The following is a description of a gene set: To study effects of IFNalpha treatment on monocyte-derived macrophages which may influence susceptibility or resistance to HIV. Genes down-regulated in comparison of control macrophages versus macrophages treated with interferon alpha. studied in species Homo sapiens from publication Greenwell-Wild T, Vázquez N, Jin W, Rangel Z, Munson PJ, Wahl SM (PMID 19556424) Human Gene Set: GSE16755_CTRL_VS_IFNA_TREATED_MAC_DN, and this is the list of marker genes: SLC5A10, TRIM56, NEURL3, FAS, EIF2AK2, POLR3C, STK17A, IRF1, NMI, EBI3, C3orf52, LINC02762, POU3F4, ICAM1, HIVEP2, NUB1 (negative regulator of ubiquitin like proteins 1), OSGIN2, RNF115, SAV1, NLRC5, DCP1A, THAP3 (THAP domain containing 3), IL7R, SYT12, DENND5A, ASH1L-AS1, SMARCE1 (SWI/SNF related, matrix associated, actin dependent regulator of chromatin, subfamily e, member 1), MIR3945HG, BTN2A1, IDO1, HAPLN3, ABTB2, PSMA2, SP110, HESX1, MCOLN2, ATP10A, TRAF1, SEMA3C, WNT5A, BASP1, DUSP5, CXCL10, IL6, FEM1C, SINHCAF, RAB8B, GMPR, OAS3, KIF12, LYN, ZC3HAV1, BCL2L13, SERPINB9, PSMB8, FSD1L, NECTIN2, RNF138, CD40, TNFSF10, NT5C3A, ADPRM, IGFBP4 (NCBI Gene Id 3487), ELL2, ISG15, RNF24, LINC00158, NBN, TNIP3, HS3ST3B1, DHX58, B4GALT5, BMAL2, CXCL11, PSMB9, AKIRIN2, SFT2D2, DYNLT1, C4orf46, HERC6, DNAJB6, GK, PXYLP1, STX11, RIGI, BCL2, LRP12, PPP2R2A, SRGAP2C, TRAFD1, APOL3 (apolipoprotein L3), STK26, RELA, TDRD7, PSEN1, PTGS2, FAM236A, SOD2, FUT4, TRIM21, PELI1, KIAA0040, ASIC3, VCAM1, IFIH1, JAK2 (NCBI Gene Id 3717), SLC2A6, MYD88, TOR1B, EDEM1, TICAM1, CD38, PSMA6, NFKBIA, DUSP16, MASTL, SAMD9L, LAP3, MAD2L1BP, JAG1, BATF2, ATP2B1, SDC4 (NCBI Gene Id 6385), PML, ZBED1, DYRK3, CDC42EP4, TNFAIP8, LAMP3, FHIP2A, IER5, IL2RA, PDGFRL (platelet derived growth factor receptor like), IFI35, GRAMD2B, IFITM1, DTX3L, SRC, AGRN, ADA, GBP5, GBP1, TEX30, PLAGL2, IDO2, PPM1K, NCOA7, PARP12, MINDY3, SLC25A28, RICTOR, IL10RA, STAT4, SOCS3, AHI1-DT, PDSS1, USP15, CD274, SERPINB2, RNF114, SSB, CDC42SE1, CYLD, RBM43, IRX4, GPR35, PPP4R2, TRIM26, RNF19B, IL15, IFI44, TENT5A, MSC (musculin), CMPK2, CFB, CXorf65, C3orf38, GUCY1A1, CCSER2, STAT2, ELOVL7, GFPT2, ARID4B, ZC3H12A, ACVR1B, N4BP1, MARCKS, SLC31A2, MAML2, RIF1, GBP2, IQSEC3, ELF4, NEMP1, PDGFA, DENND4A, CDKN1A, UBE2D3, TNFSF9